Given this list of marker genes Disp2, Mettl23, Atp5mk, Glp1r, Brd4, Npas1, Ctbp1, Pax5, Dnajc8, Clcn4, Mir7b, Neurod4, Syt14, Rph3a, Uba52, Rhbdd3, Jmjd6, Ints13, 5330439K02Rik, Mamdc4, Kars1, Unc80, Kcns2, Kcnb1, Actl6b, Grin1, Adgrb3, Snord55, Ankhd1, Rpgrip1, Lag3 (lymphocyte-activation gene 3), Mrpl49, Slx4, Ino80dos, Zbtb8os (NCBI Gene Id 69599), Kmt5c, Chrnb2, Wdr20, Orc1 (origin recognition complex, subunit 1), Asphd1, Gprin1, Nr2f6, Ppp1r9a, Ino80d, Gpr158 (NCBI Gene Id 241265), Lrp11, Ifna13, Ncdn, Shank1, Gad2, Sec14l5, Snord118, Prune2, D6Wsu163e, Glra1, Pdlim7, Frmd8os, Neat1 (NCBI Gene Id 66961), Iqank1, Mbtps2, Mapk11, Ctxn2, Slc39a3, 1110018N20Rik, Barhl1, Hrh3, Scrt1, Fbll1, Ogdhl, Maf1, Olfm3, Senp6 (NCBI Gene Id 74825), Ccdc92b, Gne, Hnrnpd, Plcd4, Unc13a, Lrrc24, Ccnk, Sharpin, Prpf38a, Cpne4, Snord2, Sinhcaf, Eif4a2, Mir6236, Cog8, Lhfpl5, Lhx3, Asic3, Tmem179, Npdc1, A630072M18Rik, Marchf4, Srrm3, Appbp2os, Rps8, Omg, Htr5a, Gm26330, Rnf4, Gnasas1, Grm2, Hspe1, Hhatl, Cd164, Sntg1, Traf3ip2, Cyb5r4, Pprc1, E2f4, Hpca, Nppb, Eri3, Fip1l1, Dglucy, Slc25a39, Kcnk12, Srebf1, Krt86, Faah (NCBI Gene Id 14073), Rbbp4, Rsrp1, Mir1932, Hes2, Ube2i, Vgf, Synj1, Traip, Scn3b, Cacng2, Meis3, Ldb1, Tph2, Sez6l2, Gapdh, BC049715, Stx1a, Gps2, Actn2, Arl2bp, Slc39a9, Svop, Mapk8ip2, Ift122, Chac1, Arsg (NCBI Gene Id 74008), Sdf4, Psph, Cacng3, Wbp11, Rbm39, AU040320, Plagl1, Ramp2, Gna11, Gt(ROSA)26Sor, Tubb5, Cartpt, Psat1, Lamc3, Oplah, Oprm1, Scg2, Zfx (zinc finger protein X-linked), Yif1a, Nxph1, Nrxn1, here is a description of the gene set: Genes containing one or more binding sites for (Zfp979_UNIPROT_Q8K293_UNREVIEWED) in their promoter regions (TSS -1000,+100 bp) as identified by GTRD version 20.06 ChIP-seq harmonization. studied in species Mus musculus Mouse Gene Set: ZFP979_UNIPROT_Q8K293_UNREVIEWED_TARGET_GENES from publication Yevshin I, Sharipov R, Kolmykov S, Kondrakhin Y, Kolpakov F (PMID 30445619)